The following is a description of a gene set: Biological oxidations studied in species Mus musculus Mouse Gene Set: REACTOME_BIOLOGICAL_OXIDATIONS, and this is the list of marker genes: Glyatl3, Ugt1a7c (UDP glucuronosyltransferase 1 family, polypeptide A7C), Gsta2, Cyp4a29, Tbxas1 (thromboxane A synthase 1, platelet), Adh7, Cyp4f14, Nr1h4, Cyp4f15, Papss1, Acy3, Mgst1 (microsomal glutathione S-transferase 1), Cyp24a1, Adh1, Nat2, Cyp39a1, Maoa, Cyp7b1, Ggt1, Acsm5, Mtrr, Cyp26b1 (NCBI Gene Id 232174), Gstk1 (glutathione S-transferase kappa 1), Cyp7a1, Glyat, Acsm2, Ptges3, Fmo2, Sult1c2, Gsta13, Cyp21a1, Aldh1b1 (NCBI Gene Id 72535), Tpst1, Cyp1b1, Sult4a1, Cyp2a4, Ces2b, Sult1e1, Comt, Hpgds, Gstm5, Adh5 (alcohol dehydrogenase 5 (class III), chi polypeptide), Sult1a1, Arnt, Cyp2c29, Ugt2a3, Cyb5b, Cyp4v3, Cyb5r3, Aoc1, Acy1, Ephx1, Cyp11b1, Gsta1, Sult2a2, Cyp2c65, Cyp2b23, Cyp2e1, Ugt2b35, Cyp4a12a, Ugt3a2, Gsta3, Ces1d, Gstm1, Gstm3, Ugt2b1, Cyp51, Dpep1, Aldh1a1, Gstz1, Cyp3a16, Cyp3a13, Ggt5, Adh4, Cyp11a1, Cyp1a2, Cyp3a11 (cytochrome P450, family 3, subfamily a, polypeptide 11), Cyp26a1, Cyp2s1, Aldh3a1, Ugdh, Ahcy, Nat3, Nnmt, Aoc2, Acss2, Cyp26c1, Aldh2, Cyp4a14, Cyp27b1, Nqo2, Cyp4f40, Chac2, Mtr, Cyp3a44, Ugt1a6a, Pomc, Cmbl, Cyp1a1, Aadac, Cyp3a41a, Ugt1a2, Cyp2a12, Cyp2f2, Ces3b, Gstm4, Ugt1a9, Gstt1, Hsp90ab1, Fdxr, Cyp2w1, Uxs1, Fdx1, Cyp3a57 (NCBI Gene Id 622127), Acsm4, Ugt1a8, Mtarc1, Rxra, Cyp2a22, Aoc3, Gstm2, N6amt1, Cyp4a10, As3mt, Ugt2b34, Cndp2, Nat1, Gstm6, Slc35b3, Ptgis, Ugt2b37, Fmo1, Abhd14b, Slc35b2, Gclm, Cyp4b1, Sult1b1, Bphl, Ugt2b5, Ugt3a1 (UDP glycosyltransferases 3 family, polypeptide A1), Trmt112, Sult2a1, Gstt2, Ahrr, Cyp4a30b, Smox, Gstm7, Ncoa2, Cbr3, Acsm1, Ugt1a1, Podxl2 (NCBI Gene Id 319655), Mat1a, Ugt2a2, Ncoa1, Cyp2a5, Akr1a1, Paox, Cyp2u1, Ahcyl, Cyp4f18, Fdx2, Ahr, Cyp3a25, Cyp4a12b, Slc35d1, Cyp4a32, Cyp46a1, Dpep2, Sult6b1, Cyp2d22, Cyp3a41b, Ggct, Mat2b, Maob, Gss, Esd, Ugt2b36, Ugt2b38, Aip, Gclc, Cyp11b2, Slc26a2, Ugp2, Cyp8b1, Tpmt, Oplah, Cyp4a31, Papss2, Ugt2a1, Mtarc2, Mgst2, Abhd10, Fmo3, Cyp2r1, Akr7a5, Arnt2, Cyp2j6, Cyp3a59, Ggt7, Slc26a1, Cyp19a1, Bpnt2 (3'(2'), 5'-bisphosphate nucleotidase 2), Gstp1, Gstp2, Bpnt1, Cyp4f39, Tpst2, Mat2a, Cyp2c66, Gsta5, Cyp27a1, Ugt1a5, Mgst3, Acss1, Gsto2, Ggt6, Ptgs1 (NCBI Gene Id 19224), Gsto1, Chac1, Ces3a, Sult2b1